Given this list of marker genes Rptor, Hmgcr (3-hydroxy-3-methylglutaryl-Coenzyme A reductase), Crhr2, Edn2, Pnkd, Npy5r, Rgs4, Gpm6b, Erp29, Nfkbia, Ptpn11, Npvf, Tlr2, Ppp1r9a, Trh, Pawr, Nedd4l, Ucp2 (NCBI Gene Id 22228), Cd74, Nup153, Snx12, Akap5, Pde4c, Ptger4, Pacsin2, Sergef, Eny2, Insig1, Hsd3b3, Crh (corticotropin releasing hormone), Cav3, Sh2b2, Jagn1, Pfkl, Kcnh2, Ppp3cc, Apoc2l, Ankrd13b, Fam3d, Il11, Nr1h3, Inhbb, Hdac3, Nr1h2, Tacr2, Drd4, Sirt6, Kalrn, Trat1, Tmbim6, Adipoq, Atf4 (activating transcription factor 4), Hcrt, Adora1, Ank3, Stk39, Asic1, Npff, Rab23, Pde3b, Nmu, Apoc2, Neurog1 (NCBI Gene Id 18014), Abr, Idua, Ccn3, Drd3, Npy2r, Tcp11, Plscr1, Picalm, Itgav, Anxa1, Sumo1, Srebf2, Igfbp3, Derl3, Kcne1, Foxo1, Trdn, Pip4p2, Fcrl5, Siglece, Tnfrsf1a, Vdac1, Npsr1, Mup2, Edn3, Tff2, Htr6, Htr2a, Vip, Tbc1d1, Adcyap1, Tbc1d4, Wdr54, Pde1c, Gabbr1, Fkbp1b, Prtn3, Os9, Gnao1, Epo, Crbn, Acacb, Srcin1, Zfas1, Hrc, Prkg1, Rab11fip3, Abcc8, Pacsin3, Neo1, Nmb, Wnk4, Maob (monoamine oxidase B), Tspo, Ptprv, Ada, Rab11fip5, Sestd1, Pkd2, Pik3c2a, Vsnl1, Chp1, Slc15a1, Kcne2, Mtmr4, Pacsin1, Cnih2, Ppp3ca, Mmp9, Ceacam1, Oaz1, Gnai1, Bard1, Acvr1c, Entpd1, Pde8b, Tgfb1, Camk2d, Nos1, Yod1, P2ry12, Cbarp, Akap1, Apoe, Akt2, Snx3, Ywhaq, F2rl1, Snph, P2ry1, Slc43a1, Sh3gl3, Cyp51, Hmox1, Ubqln2, Nrg1, Myc, Cd200, Drd2, Kcnk9, Cers1 (NCBI Gene Id 93898), Tgfb2, Ywhab, Agrn, F2r, Slc26a5, Tsc2, Acsl4, Adtrp, Rap1a, Mdfic, Atp1a2, Chga, Hsd3b6, Serpine2, Hadh, Apoc3, Prrt2, Atp7a, Pkig, Bcl2, Ppm1f, Rest, Atxn2, Rangap1, Lyplal1, Bin1, Wnk2, Sftpd, Sct, Gnaz, Ifnb1, Egf, Mup1, Madd, Il6, Ggcx, Prkn, Plcb4, Cacna1f, Kcnab1, Map1b, Sp100, Prkcb, Calm2, Trim9, Wnk1, Abca7, Vamp8, Slc18a2, Gsk3a, Cd36, Pparg, Ei24, Gpr39, Grp, Mrln, Spink1, Gsto1 (NCBI Gene Id 226190), Hbp1, Ahi1, Svip, Lgals9, Syt4, Ywhae, Arhgap8, Prkg2, Ptk2b, Pkdcc, Map4k4, Il1rn, Il1rapl1, Mup3, Npy1r, Pten, Angpt1 (angiopoietin 1), Gja1, Erlec1, Smcr8, Ghrl (NCBI Gene Id 80454), Cryaa, Sirt1, Gbp4, Ndfip1, Atp9a, Cnn2, Enpp1, Erbb3, Casq2, Mtmr2, Ubac2, Ptgs1 (NCBI Gene Id 19224, prostaglandin-endoperoxide synthase 1), Hnf4a, Rab11fip1, Rack1, Crhr1, Ace, Fgf23, Sirt4, Prom2, Anxa5, Anxa2, Tnfrsf1b, Best3, Arl6ip5, Ptpmt1, Rab7, Lrsam1, Snx33, Mtor, Prkca, Nedd4, Inpp5k (NCBI Gene Id 192772), Ucn, Htr7, Dlg4, Ffar2, Htr1b, Ubqln1, Hrh2, Pla2r1, Fmr1, Cryab, Sri, Commd1, Fis1, Lep, Mtnr1b, Inha, Hsd3b2, Rhoq, Gpr35, Neu3 (NCBI Gene Id 50877), Oxsr1, Itgb3, Fabp5, Cdk5, Hmgb1, Kcnb1, Cav1, Lrrtm2, Osm, Kcnrg, Mup4, Tpr (translocated promoter region, nuclear basket protein), Eppin, Ndufaf2, Ffar4, Cry2, Fcgr2b, Iscu, Prkce, Cd300lf, Ube2g2, Edn1, Pid1, Grk2, Cd47, Rem1, Gnb5, Myo5a, Ins1, Atg5, Wdr41, Fbn1, Rbm10, Mcub, Atp5pf, Cnr1, Klf7, Vps35, Slc30a1, Ppp3r2, Adra2a, Irs1, Ddx39a, Gstm7, Gnai2, Nucb2, Coro1a, Stxbp5l, Lypla1, Ptger3, Tnf, Pou5f1, Mapt, Epha3, Ankrd13a, Arhgap1, Lgals3, Oaz3, Lif, Abca2, Rsad2, Ufm1, Cttnbp2nl, Pim3, Rhbdf2, Park7, Cd300a, Lrrtm1, Il1b, Tlr9 (toll-like receptor 9), Hamp, Ghsr, Il12b (NCBI Gene Id 16160), Derl2, Icam1, Apoc1, Tifab, Oprk1, Kel, Uts2, Notch1, Arfip1, Rgs2, Ins2, Pea15a, Rab33b, Il12a, Dph3 (NCBI Gene Id 75408), Stxbp3, Pla2g10, Psmd9, Calm1, Rin3, Wwp2, Sdcbp, Ccr2, Oprm1, Csk, Ntsr1, Mctp1, Ndfip2, Nckap1l, Foxf1, Dysf, Pln, Oaz2, Unc119, Stc1, Kcne3 (NCBI Gene Id 80572), Ahr, Ostn, Slc18a1, Vamp3, Actn2, Rhbdf1 (NCBI Gene Id 13650), C9orf72 (NCBI Gene Id 73205), Nf1, Nherf1, Mtnr1a, Mup5, Smim6 (NCBI Gene Id 68528), Upk3b, Appl1, Kcnj6, Sln, Ppp3cb, Cabp1, Scamp5 (NCBI Gene Id 56807), Kcne5, Apoa2, Atg3, Vps4b, Midn, Mup11, Ube2j1, Sfrp1, Ffar3, Ubr3, Stx1b (NCBI Gene Id 79361), Appl2, Ptgs2, Braf, Shh, Spi1, Abat, Cyfip1, Kcnj11, Kcnq1, Sfrp4, Usp2, Snca, Sytl4, Ankrd13d, Gnaq, Cd84, Slc43a2, Wfdc6a, Cry1, Pcsk9, Frmd4a, Il13ra2, Wnk3, Esr1, Calm3, Pxk, Trim27, Ppif, Agtr2, Atg7, Fbxo11, Nos3, Irak1, Txn1, Pkia, Lrpap1, Rabgef1, 1810037I17Rik, Ankrd27, Ppp3r1, Fermt1, Thbs1, Crhbp, Rap1b, Sar1a, Htr1a, Irs2, Syt11, Gopc, Yrdc, Ucn2, Fam76b, Sirpa, Rubcn, Grb10, Hes1, Bcr, Spx, Apod, Osr1, Idh2, Gck, Cartpt, Hrh3, Hamp2, Akt1, Srebf1, Necab2, Grm7, here is a description of the gene set: species: Mus musculus Any process that stops, prevents, or reduces the frequency, rate or extent of the directed movement of substances (such as macromolecules, small molecules, ions) into, out of or within a cell, or between cells, by means of some agent such as a transporter or pore. Mouse Gene Set: GOBP_NEGATIVE_REGULATION_OF_TRANSPORT